The following is a description of a gene set: electronically inferred by orthology from the curated human pathway This event has been computationally inferred from an event that has been demonstrated in another species.<p>The inference is based on the homology mapping from PANTHER. Briefly, reactions for which all involved PhysicalEntities (in input, output and catalyst) have a mapped orthologue/paralogue (for complexes at least 75% of components must have a mapping) are inferred to the other species. studied in species Mus musculus Reactome Pathway: p53-Dependent G1 DNA Damage Response part of: p53-Dependent G1/S DNA damage checkpoint, and this is the list of marker genes: Psmd12, Psma3, Rps27a, Psma6, Psma1, Psmc6, Psma4, Cdkn1b, Psmc3, Psmd6, Psmd1 (proteasome (prosome, macropain) 26S subunit, non-ATPase, 1), Psmd13, Psmc4, Psmb4, Psmb6, Chek2, Ccna1, Ubb, Psma7, Zfp385a, Psma2, Psmb5, Psmc2, Cdkn1a, Psmd7, Psmc5 (NCBI Gene Id 19184), Psma5, Phf20, Psmb7, Psmc1, Ccne2, Ccne1, Trp53